Given this list of marker genes GPR132, PSME3, HECW2, E2F7, BABAM2, FBXO31, FEM1B, MAP3K11, KNTC1, DUSP1, PLK3, ZNF16, MBTPS2, CALM2, CRY1, DNM2, KMT2E, MIR15A, OVOL1, ZFP36L2, DACT1, PHF10, DLG1, NEK10, CDK17 (cyclin dependent kinase 17), MIR16-1, SOX2, PHF8, MTA3, RBL1, GEN1, ATR, CCNE1, PKMYT1, FAM83D, H2AX, CDK15, MIR520H, POLE, PIM2, DYRK3, NABP1, KNL1, PTPN6, SIX3, AVEN, SASS6, HINFP, AKT1, MACROH2A1, STK33, MYO16, CCNB3, TERT, TRIAP1, PIAS1, NES, CRNN, RNASEH2B, ARID2, ATM, PPP2CA, CACNB4, BCL2, MIR195, RBL2, RIOK2, SKP2 (NCBI Gene Id 86997), PRAP1 (NCBI Gene Id 118471), CDC45, CDC23, ATP2B4, TRIM39, SPAST, GPR15LG (NCBI Gene Id 387695), MN1, ACTB (actin beta), KLHL18, MIR29A, CDK14 (NCBI Gene Id 5218), MIR133B, CCND2, RPS27L, RPA4, ENSA, SKA3 (spindle and kinetochore associated complex subunit 3), RRM1, FZR1, UBE2A, CALM1, CUL4A, MAD2L1, CDK18, PAF1, ITGB1, DGKZ, NEK11, GLI1, CDC16, CCNI2, RFWD3, TPRA1 (NCBI Gene Id 63108), FOXO4, CDC6, PPP6C, SMARCA4, EIF4E, CCNA2, CDK5RAP3, PSME1, MIR503, TCF3, CHMP4C, BRCA2, PSME2, CDK3, BID, GFI1B, CCNG2, CCNE2, GNB1L, TBX2, HSPA2, XPC, ADAMTS1, VPS4A, BCL7B, ERCC2, MIR10A, AKAP8L, WEE1, CDKN2D, ESPL1, CDKN2C, CHMP4B, MIR495, SLFN11, DDR2, CDK2AP2, PPME1, PLCG2, HEXIM2, GSPT1, UIMC1, BUB3, RAD1, CHFR, DYNC1LI1, KLF11, ANAPC11, GPNMB, KLHL22, PKIA, TFDP1, RAD9B, PBRM1, ID2, SMC5, EME2, STIL, PTEN, CUL4B, UFL1, BUB1, CTDSP1, TREX1, MRNIP, ATF5 (activating transcription factor 5), VPS4B, USP44 (NCBI Gene Id 84101), CCNJL, TEX14, MLF1, RAD21, TAF2, BRCC3, TIMELESS, MAPK15, JADE1, RBBP8, STK38 (serine/threonine kinase 38), MDM2, MAP3K20, FBXO4, RPTOR, CDKN2B, RAD51B, SMARCD1, APPL1, TRIP13, TM4SF5, PPM1D (NCBI Gene Id 8493), ZNF207, CDC73, CDKN3, DNA2, FBXL7, ANAPC7, CDC20, MIR222, MAD2L1BP, CDC14A, TPR, MIR15B, MIR133A1, CCL2, MAD2L2, CCNO, MNAT1, CHEK1, PKP3, APBB2, NBN, APPL2, RPA2, HASPIN, PPP1R10, ACVR1, CHMP7, MBTPS1, DBF4, ZW10, NDC80, PBX1, CAMSAP3, CCNA1, RRM2B, FGF10, PAGR1, SMARCA2, BCAT1, BRD7, CDC25B, ECD, CLASP1, ANAPC2, TPD52L1, RFPL1, E2F3 (E2F transcription factor 3), RHOU, ANAPC4, EIF2AK4, CUL2, SPC25, MEPCE, NUF2, NSUN2, CACUL1, BRIP1, XRCC3, PPP1R9B, KLF4, FBXO7, TGFB1, PKD1 (NCBI Gene Id 5310), NEUROG1, DPF3, NSMCE2, CDKN1B, CUL5, TAOK1 (NCBI Gene Id 80214), BTN2A2, ADAM17, MIR638, MIR29C, SUSD2, NFIB, INIP, SETMAR, PROX1, MOS, ZNF324, ANAPC5, ACVR1B, MASTL, FBXO6, PRP4K, CYP1A1, SPDYA, MIR137, FAM107A, UPF1 (NCBI Gene Id 5976), PLK5, DCUN1D3, BCL7A, MIR362, EIF4EBP1, LSM11, MIIP, CKS2, PKD2, HORMAD1, ERCC6 (ERCC excision repair 6, chromatin remodeling factor), MIR29B1, PPP3CA, CLSPN, CDK2, TCIM, CCNB2, RDX, HUS1B, CCNI, UBE2L3, CDK1, CDK6, GTPBP4, MIR873, CHMP2A (NCBI Gene Id 27243), CDKN2A (cyclin dependent kinase inhibitor 2A), TP53BP1, NOP53, CDC14C, FBXL15, INHBA, DDRGK1, WNT10B, RASSF1, TP53, TAOK3, IQGAP3, CCNQ, DBF4B, CRLF3, MDC1, TP63, CUL1, STXBP4, CDC7, MRE11, PTPRC, PSMG2, TAF10, ANAPC15, CCNY, SMARCD2, SDE2 (SDE2 telomere maintenance homolog), RAD51C, DPF1, USP17L2, PARP9, LYN, CHEK2, CDKN1A, CDC5L, RCC1 (NCBI Gene Id 751867), DTX3L, ZNF655, SMARCD3, EPS8, BARD1, NANOGP8, MUC1, ZWINT, MIR221, ACTL6A, SYF2, BABAM1, ID4, LATS1, CCNB1 (NCBI Gene Id 891), ARID1B, ZFP36L1, CCNH, STOX1, KHDRBS1, FOXM1, KDM8 (NCBI Gene Id 79831), CDC14B (NCBI Gene Id 8555), PHOX2B, USP37, SMARCE1, CCNF, PAXIP1, IER3, ATRIP, CDK16, RB1, ARPP19, EME1, CENPJ, RPL24, FBXW7, ANAPC1, CAMK2A, CCNJ (cyclin J), CEP63, CDK7, SMARCC2, PLK2, DPF2, SIRT2, ZC3H12D, EIF4G1, ZWILCH, CDC25C, CDT1, UBE2C, BLM, TTI2, PLCB1, MIR193A, MIR26A1, STK35, RINT1, INTS3, FHL1, SENP2, RAD50, INTS7, RHNO1, PLRG1, PABIR1, LCMT1, TMOD3, IK, SMARCC1, TMSB4X, TRIM71, TIPRL, NABP2, SPDL1, KIF14, CCNG1, CTDSP2, CDCA8, ZNF830, ZFYVE19, CDKN1C, NPAT, MIR892B, PDIK1L, CENPF (centromere protein F), ANXA1, RAD9A, RGCC, CCAR2, DONSON, EGFR, CDK5, SIN3A, TFDP3, CDK10, MIR19B1, MBLAC1, BRSK1, MIR520A, ABCB1, TICRR (NCBI Gene Id 90381), ANKRD17, MYB, MUS81, SMARCB1, ATF2, CDCA5, CDC27, MTBP (MDM2 binding protein), TFAP4, MIR208A, FANCD2, ERCC3, USP26, ATAD5, CDC34, ORC1, MIR451A, CTC1, USP28 (NCBI Gene Id 57646), TTK, AURKA, ETAA1, RAD17, NPM2, WAC, MARK3, CCND1, MYC, NPM1, NEK6, CALM3, SKA1, MIR30C2, NFIA, DDB1, PRKDC, RAB11A, CUL3, TTI1, CPSF3, MIR372, MSH2, APBB1, PPP2R2D, KCNH5, TMEM14B, LSM10, CENPE, UBE2S, BRD4, EZH2, UBD, HUS1, CLASP2, MAD1L1, UBE2E2, E2F1, INO80, MAPK14, RRM2, MIR214, FOXN3, ING4, AIF1, CDK4, PRMT2, CCDC57, CLOCK, FBXO5, ARID1A, USH1C, KCNA5, ACTL6B, NAE1, BRSK2, BCL7C, CDK5RAP2, LATS2, USP22, PTPN11, CDC25A, INCENP, ABRAXAS1, TOPBP1, BRCA1 (BRCA1 DNA repair associated), DLGAP5, CTDSPL, SPC24, MIR519D, DTL, BIRC5, TELO2, CTDP1, MELK, DDX3X, WDR76, APC, USP50, PINX1, RAD51, RCC2, CCND3, ANLN, TACC3, RPS6KB1, PRPF19, PLK1, CCNP, AMBRA1, KANK2, AURKB, USP29, TIPIN, TAOK2, GIGYF2, BUB1B, MIR515-1, AKAP8, DBX2, DOT1L, PTENP1-AS, TAF1, here is a description of the gene set: Human Gene Set: GOBP_CELL_CYCLE_PHASE_TRANSITION species: Homo sapiens The cell cycle process by which a cell commits to entering the next cell cycle phase.